Given this list of marker genes LEP, APOA2, CEL, LPCAT3, CD36, PNLIP, LDLR, AKR1C1, APOA1, SOAT2, LIMA1, APOA4, ENPP7 (ectonucleotide pyrophosphatase/phosphodiesterase 7), ABCG5, CYP8B1, ABCG8, NPC1, NPC1L1 (NCBI Gene Id 29881), here is a description of the gene set: studied in species Homo sapiens Uptake of cholesterol into the blood by absorption from the small intestine. Human Gene Set: GOBP_INTESTINAL_CHOLESTEROL_ABSORPTION